The following is a description of a gene set: species: Homo sapiens Adrenal hyperplasia Human Gene Set: HP_ADRENAL_HYPERPLASIA Enlargement of the adrenal gland., and this is the list of marker genes: USP48, STAR, TBC1D24, ARMC5, AIRE, CYP11B2, CYP17A1, HSD3B2, ATRX, CLCN2, NR3C1, CYP11B1, GNAS, POR, CACNA1D, CYP21A2, CDH23, TP53, PRKACA (protein kinase cAMP-activated catalytic subunit alpha), USP8 (NCBI Gene Id 9101, ubiquitin specific peptidase 8), BRAF, KDM1A, ATP6V1B2, PDE8B, KCNJ5